The following is a description of a gene set: species: Mus musculus Purine metabolism Mouse Gene Set: WP_PURINE_METABOLISM, and this is the list of marker genes: Uox, Xdh (NCBI Gene Id 22436), Pfas, Entpd6, Pde10a, Pde6a, Pde6d, Adsl, Impdh2, Polr1h, Gucy2d, Entpd4, Polr1a, Entpd4b, Pole3, Prps1, Polr3f, Polr3h, Pde4d, Pnp2, Gmpr, Prim1, Polr1b, Papss2, Polr2i, Pde5a, Rrm2b, Entpd1, Pola2, Allc, Adcy1, Nudt16, Nudt16l2, Polr2f, Pde2a, Adcy7, Nme7, Ampd1, Adcy4, Polr3c, Ak4, Pold1, Urah, Pde6h, Prps2, Pnpt1, Gucy2c, Pde7b, Polr3d, Impdh1, Gucy1a1 (NCBI Gene Id 80637), Polr2l, Prps1l1, Nt5e, Polr3gl, Gda (guanine deaminase), Ak8, Npr1, Rrm1, Ak6, Nt5c1b, Polr3g, Pde3b, Adprm, Pde6c, Dguok, Nt5c3, Rrm2, Ak1, Nudt9, Adss1, Nt5c1a, Entpd8, Gucy1b1, Polr1e, Pde11a, Gucy1b2, Pde4c, Urad, Nme4, Polr2d, Hddc3, Polr3k, Hprt1, Fhit (NCBI Gene Id 14198), Nt5c2, Polr2j, Pde4b, Gart, Adcy6, Nudt5, Nme3, Pde8a, Entpd3, Prim2, Nme6, Ak9, Pnp, Pola1, Gmpr2, Itpa, Ak7, Ampd3, Pde3a, Pole4, Cant1, Ampd2, Adcy9, Ada, Pold2, Polr2e, Pole, Polr3b, Prps1l3, Pde6b, Guk1, Adss2, Pgm1 (phosphoglucomutase 1), Papss1, Gmps, Pold4, Adcy5, Pde8b, Prune1, Nt5c, Dck, Pde1b, Polr2b, Polr2g, Polr3a, Entpd5, Ppat, Nme5, Adcy2, Nme1, Gucy2f, Pde6g, Polr1c, Entpd2, Pold3, Pgm2, Adcy8, Adcy3, Pde4a, Nudt2, Polr2c, Pole2, Pkm, Paics, Atic, Ak2, Polr2a, Gucy1a2, Aprt, Adcy10, Taf9, Npr2 (NCBI Gene Id 230103), Pde1a (NCBI Gene Id 99336), Nt5m, Pde1c, Gucy2e, Enpp1, Adk (adenosine kinase), Ak5, Pde7a, Polr3e, Polr1d (NCBI Gene Id 97252), Enpp3, Polr2h, Pklr, Nme2, Pde9a